The following is a description of a gene set: Reactome Pathway: NRAGE signals death through JNK part of: Cell death signalling via NRAGE, NRIF and NADE species: Homo sapiens Once bound by either NGF or proNGF, p75NTR interacts with NRAGE, thus leading to phosphorylation and activation of JUN Kinase (JNK). JNK controls apoptosis in two ways: it induces transcription of pro-apoptotic genes, and directly activates the cell death machinery. Only NGF-bound p75NTR is shown here., and this is the list of marker genes: PLEKHG2, RAC1, ARHGEF40 (Rho guanine nucleotide exchange factor 40), OBSCN, MAPK8 (mitogen-activated protein kinase 8), MCF2, PREX1, MCF2L, ARHGEF18, RASGRF2, GNA13, ARHGEF11, VAV1, NET1, BCL2L11, ARHGEF37, FGD3, MAGED1, ARHGEF35, FGD1 (FYVE, RhoGEF and PH domain containing 1), PLEKHG5, TIAM1, FGD4, ARHGEF26, SOS2, ARHGEF3, ECT2 (epithelial cell transforming 2), ARHGEF10, ARHGEF33, AKAP13, ARHGEF38 (Rho guanine nucleotide exchange factor 38), ARHGEF9, ITSN1, ARHGEF12, TRIO, NGF, NGEF, ARHGEF16, ARHGEF5, VAV3, ARHGEF39, AATF, ARHGEF17, ABR, ARHGEF15, SOS1, KALRN, ARHGEF1, ARHGEF2, BAD, VAV2, ARHGEF7, ARHGEF19, FGD2, ARHGEF10L (Rho guanine nucleotide exchange factor 10 like), TIAM2, NGFR, ARHGEF6, ARHGEF4